The following is a description of a gene set: studied in species Homo sapiens Epigenetic silencing in cancer cells is mediated by at least two distinct histone modifications, polycomb-based histone H3 lysine 27 trimethylation (H3K27triM) and H3K9 dimethylation. The relationship between DNA hypermethylation and these histone modifications is not completely understood. Using chromatin immunoprecipitation microarrays (ChIP-chip) in prostate cancer cells compared to normal prostate, we found that up to 5% of promoters (16% CpG islands and 84% non-CpG islands) were enriched with H3K27triM. These genes were silenced specifically in prostate cancer, and those CpG islands affected showed low levels of DNA methylation. Downregulation of the EZH2 histone methyltransferase restored expression of the H3K27triM target genes alone or in synergy with histone deacetylase inhibition, without affecting promoter DNA methylation, and with no effect on the expression of genes silenced by DNA hypermethylation. These data establish EZH2-mediated H3K27triM as a mechanism of tumor-suppressor gene silencing in cancer that is potentially independent of promoter DNA methylation. from publication Kondo Y, Shen L, Cheng AS, Ahmed S, Boumber Y, Charo C, Yamochi T, Urano T, Furukawa K, Kwabi-Addo B, Gold DL, Sekido Y, Huang TH, Issa JP (PMID 18488029) Genes with high histone H3 tri-methylation mark at K27 (H3K27me3) in SW48 cells (colon cancer), by ChIP-chip assay on a 12K CpG array (high-CpG-density promoters, HCP). Human Gene Set: KONDO_COLON_CANCER_HCP_WITH_H3K27ME3, and this is the list of marker genes: IGHV4-31, RARB, YBX2, IGHG1, CPNE4, ST20